The following is a description of a gene set: Binding to the reduced form, NADH, of nicotinamide adenine dinucleotide, a coenzyme involved in many redox and biosynthetic reactions. Mouse Gene Set: GOMF_NADH_BINDING studied in species Mus musculus, and this is the list of marker genes: Aldh2, Qdpr, Rnls, Hsd17b8, Cryz